The following is a description of a gene set: Mouse Gene Set: GOBP_AMINO_ACID_NEUROTRANSMITTER_REUPTAKE The uptake of amino acid neurotransmitters by neurons or glial cells. This process leads to inactivation and recycling of neurotransmitters. studied in species Mus musculus, and this is the list of marker genes: Slc17a8 (solute carrier family 17 (sodium-dependent inorganic phosphate cotransporter), member 8), Kcnj10, Itgb1, Cln8, Per2